Given this list of marker genes NIPSNAP2, ZFYVE26, SYT17, GAS2L1, LAMB2, DOP1B, NKRF, GMFG, FCER2, DHX38 (DEAH-box helicase 38), SGTA (NCBI Gene Id 6449), CUL4A, RPP38, EEF1B2, AIMP2, KDELR1, PLXNB2, ATPAF2, PWP2, CD9, C1QBP, USP7, WDR7, CBR3, ZNHIT1, UBA2, GFRA2, RPS14, STOML2, AIMP1, ZMIZ1, TMEM243, SZT2, ZC3H15, DCAF8, RGS10, CBX7, TUFM, SIVA1, SPHK2, ANP32B, DEAF1, UPF3A, TMEM158, ZWINT, CCT4, ERF, CSK, ADORA3, FOXN3, H2AZ1, CBR4, TLE4, HELZ, TBC1D8, CDC123, NBAS, TXNL4A (thioredoxin like 4A), LTA4H, CPVL, LILRA2, ANP32A, SEPTIN9, CDC5L, GCSH, ABCD3, KLHL21, PECAM1, MPST, TTPA, ALDH2, AATF, WIPI2, THAP12, DAP, YWHAH (tyrosine 3-monooxygenase/tryptophan 5-monooxygenase activation protein eta), TKT, NDUFS7, BRPF1, ATXN2L, MLEC, HDLBP, LMO4, GDE1, RAC2, RNASE6, TAX1BP3, PPM1B, F13A1, INPP1, AHCYL1, HS3ST1, CCNI, EIF1AX, SLCO2B1, TIMP2, TBC1D22A, TBC1D1, ASMTL, HRH1, STRAP, TPM1, TUSC2, SOCS1, ADCY9, PHB2, AP1B1, HEXB, SART3, CD300A, CLEC10A (NCBI Gene Id 10462), RNF11 (ring finger protein 11), CLIP2, PUF60, FURIN, CAMK1 (NCBI Gene Id 8536), HERC2P3, DHRS3, ICAM3, PFKFB1, OFD1, APOC1, PON2, SELENOP, PUM1, PABPC4, EIF3F, ID3, SCARB1, ADAM15, PUM2, NDUFS6, AIP, DAAM1, EIF3M, CX3CL1, ACTL6A, DDX5, SLC25A11, CHN2, TLE5, MARS1, PRMT1, S100A4, ATP5PF, BDH1, RGS19, CDH2, ZFP36L2, LYL1, ATXN2, PNPLA6, UBN1, ADD1, BAAT, DPY19L1, HYAL2, VGLL4, LMO2 (NCBI Gene Id 8051), TRRAP, ATP11B, TRAF2, UBE2D2, PCSK5, RAB9A, SLC1A5, FADD, CFD, ECH1, H2AZ2, SEC31A, HNRNPM, ERP29, SLC38A10, FKBP1B, PYGB, LY86, PLA2G5, DDX42, RAB33A, HSPA9, GATD3, ISCU, PCBP2, ARHGEF18, SNU13, SPTAN1, MAGED2, IFT20, TFAP4, TBP, HMGB2, ISG20L2, CAMTA2, TMC6, MAN2A2, NCOR2, PRKY, CLEC16A, SLC7A8, here is a description of the gene set: Genes up-regulated in comparison of dendritic cells (DC) exposed to 50 worms/well B. malayi versus DC exposed to M. tuberculosis from publication Chaussabel D, Semnani RT, McDowell MA, Sacks D, Sher A, Nutman TB (PMID 12663451) Monocyte-derived dendritic cells (DC) and macrophages (MΦ) generated in vitro from the same individual blood donors were exposed to five different pathogens, and gene expression profiles were assessed by microarray analysis. Responses to Mycobacterium tuberculosis and to phylogenetically distinct protozoan (Leishmania major, L. donovani, Toxoplasma gondii) and helminth (Brugia malayi) parasites were examined, each of which produces chronic infections in humans yet vary considerably in the nature of the immune responses they trigger. Human Gene Set: GSE360_HIGH_DOSE_B_MALAYI_VS_M_TUBERCULOSIS_DC_UP species: Homo sapiens